Given this list of marker genes VIPAS39, GSTP1, TUBGCP3, PHTF1, SH3BP5, SSNA1, GPNMB, PSPH, CRY1, ALG2, GADD45B, DERL2, PPP4R3A, ABCB8, PDE8A, DHX8, LINC02599, EIF2S3, EMC3-AS1, NEK10, CHROMR, ADRM1, TRIP12, LINC01270, PES1, SNRNP35, ATP5MC1, ZNF26, HEY2-AS1, ZSCAN31, TMEM11, C6orf226, RECQL5, RN7SL371P, GLYR1, TREX1, SRPRB, FAN1, ZNF621, ATF1, GAPDH-DT, INO80D-AS1, RPS24 (NCBI Gene Id 6229), RTCA-AS1, SLC16A13, PPP6C, SETD4, RNF212, ATG4A, CD109, NEDD8, PDCD6 (programmed cell death 6), RETREG3, AHI1-DT, EDC3, MED24, TOP3A, INVS, HSPA4, ZNF213-AS1, MUC20-OT1, DCAKD, ASXL1, CYTH1, PPP2R3C, RBM27, APOC1, ZNF592, SNRPD2, LINC00824 (long intergenic non-protein coding RNA 824), C1orf174, ZRANB2-DT, TBC1D19, SMC6, CASP8 (caspase 8), SULT1A1, EPDR1, SLC22A4, GOLGA2, TBC1D2, RHBDD3 (NCBI Gene Id 25807), LINC01287, SAR1A, PABPN1, LOXL1-AS1, IPPK (NCBI Gene Id 79194), CCT6A, MLEC, SUCLG1, NEK4, BRF2, PITPNB, PDXDC1, ZBTB38, ARIH1, HM13, AP2A2, CLN8, TCEANC2, ZNF207, GRAMD1B, SLC25A28, AFP, MRPL37, GCC2, GEN1, ARHGAP19-SLIT1 (NCBI Gene Id 100533184), ZSCAN26, MMUT, ENSG00000268460, SLC35E1, ZNF107, FOXN2, TCF7L2, CDKN2AIPNL, PSMD8, TMOD3, NXPE3, TIA1, DNAJC27, LINC02331, GTF2F2, RPL34, EHD1, COPS4, TNIP1, RNU6-304P, EHMT1, NUDC, TOR2A, LINC01888, CSTF1, CRAT, PTPDC1, EIF3L, C17orf75, HMGXB3, DYNLT2B, PMP22, SMIM7, ATG12, ENSG00000239142, LSG1, ENSG00000227101, MAP4, NAGPA, SLC7A5P2, MNT, PIPOX, BTF3 (NCBI Gene Id 689), LRP6, COQ8A, SLC25A28-DT (NCBI Gene Id 123466211), SLC48A1, ZNF148, COL7A1, CCDC18, ABHD17B, MAFG, DMRTA2, GBE1, GPRIN2, PHF12, ASCC1, PLA2R1, SAV1, RPL22L1, ENSG00000227496, CASC3, SLTM, AIDA, ANKHD1-EIF4EBP3, TDP2, NAXE, TSC1, MIS12, LANCL2, CCDC88B, POLR1G, CSNK1D, SAMD4B (sterile alpha motif domain containing 4B), KIAA1191, FAM219A, RHOA, LINC02065, MIR3912, UAP1-DT, CENPO, MAP3K3, CCDC18-AS1 (NCBI Gene Id 100131564), GNG12-AS1, MEPCE, ASH2L, RPS23, UBIAD1, SDAD1, IFRD1, RPL5, SLC7A11, GFM1, SLC39A9, PARP2, GSTM4, SPAG16-DT (SPAG16 divergent transcript), DNAI1, BHLHE40-AS1, UFL1-AS1, TMEM68, LINC00706, SNORD101, C17orf100, LINC03014, SRD5A3, LOXL1, CD63, UGGT1, BCYRN1, RNU6-92P, METTL16, PCGF1, RFFL, RAB3GAP1, ENSG00000267882, SLC35D1, PVT1, ITPRID2, ATP6AP1L, RBFA, ENSG00000266401, ZNF180, CDKN2B-AS1, SQSTM1 (NCBI Gene Id 94002), DNAJB9, XRCC5, AK5, CSF1, FAM204A, NTRAS, GEMIN8P4, LSM10, MIR4710, CEP112, USP15, POLR3F, LINC00322, RNU6-313P, RBM4, AIFM2, DGUOK, C2orf68, TM4SF19-AS1, SEC31A, NAA38, UFD1, TTBK2, EPC1, PI4KB, PCBP1, SEC24C, ECI2, MSRB1, MED31, YJU2 (NCBI Gene Id 55702), SERP1, RTEL1, ENSG00000203987, OIP5, TMEM44-AS1, HSPA5-DT, YWHAG, LAMB3, ANKHD1-DT, TAX1BP1-AS1, RBM3, TBCK, HNRNPA1, NSUN4, LINC02006, LRRC57, RNU6-1276P, TUSC1, NDUFC1, TMEM242-DT, ZNF764, FRMD4B, ZNF346, CDC23, SERBP1, YWHAE, ATP5F1B, NSL1, TNFAIP1, ALYREF, DLGAP1-AS2, PIGU, AP3S1, TINAGL1 (tubulointerstitial nephritis antigen like 1), RPL6, ARL1, PPIP5K2, CFLAR, SPTA1, AMBP, PISD, RAB24, ZNF451-AS1, VCP, PIR, ABHD12, ZRANB2 (zinc finger RANBP2-type containing 2), GTF2A1, RIC8B, SRSF2, ENO1, NUMBL, MBD4, TSC22D1, CCT8, CKS1B, SH3GLB1 (NCBI Gene Id 51100), TMED5, VPS26C, TMEM167A, ENSG00000187185, MYSM1, KBTBD4, ZSCAN22, SNHG29, CUX1, ENSG00000293341, TRIM4, ANK1, TSEN15, MIR4482, DOHH, ARL6IP6 (ADP ribosylation factor like GTPase 6 interacting protein 6), GABARAPL1, TANK, UTP18, TBC1D14, H4C8, COX14, GAPDH, PIN4, TAFA2, IFT122, NAA80 (N-alpha-acetyltransferase 80, NatH catalytic subunit), ZNF594-DT, CYP2R1, SNRPE, ZNF574 (NCBI Gene Id 64763), PAK1IP1 (PAK1 interacting protein 1), OSMR (NCBI Gene Id 9180), DCAF12, RHOF, EIF1, GYG1, VDAC2, ANXA6, BICD2, ACTR3C, ABCF3, ABHD16B, TRIM25, RABGGTB, BECN1, MIR4754, TACC2, CIAO3, GGNBP2, DDX42, RORA-AS1, AP1G1, WDR19, UPF2, C19orf53, C2orf49, NUP85, ZNF524, TAGLN2, RARS1, INPP5B, HSPA5, CARS1, WDR13, ZNF383, ATG16L2, PJA2, KNTC1, ZNF2, ZBTB20, RNPC3-DT, MXD1, LINC01063, CCDC102B, UPF3A, RPL27A, RNU6-1, GOLGA1, DDX23, GNL1, AHCYL1, MDH2, AFG3L2, PEF1-AS1, REXO1, BACH1, LINC00466, SMG1P3, HEXIM1, CNPY4, THAP9-AS1, VTI1B, SCYL3, JPT1, NADK, CRPPA, NMT1 (N-myristoyltransferase 1), POLR2A, ACTR8, HSPE1, SNAP25-AS1, STAM2, TMEM87A, TRMO, PIP5KL1, MTRR, GFI1B, GTF3C2-AS2, CTSA, SNORA57, MICOS10-NBL1, GNAL, BLMH, SLC1A1, WHSC1L2P, TXNL4A, PSMD10, CANX, WDR5B-DT, NTPCR, ADM-DT, USP39, STC2, TPM4, CASP6, BNIP1, TYRP1, WAC, MPDU1, TCAIM, SAP30BP, KIAA1328, SPRED1, GMPR2, PSMC3, FAM187A, ANKRD54, AKT1S1, FKTN-AS1, STAM, SBNO1 (NCBI Gene Id 55241), PSMD9, IQCG, DNAJB4, DCAF8, NDUFA4, ZNF619, SMC3, PSMB3, EEF1AKMT3, ABT1 (NCBI Gene Id 29777), TUBG1, CHCHD3, DENND4A, VEZF1, PDAP1, RHEBL1, APBB2, ACTMAP, LUC7L3, PRR5, FAM133B, DHRS4-AS1, MIPOL1, TUBA4A, TALDO1 (NCBI Gene Id 6888), MTMR2, UHMK1, VPS52, PCCB, MPDU1-AS1, SLC39A7, COQ8B, GGPS1, CDK11A, PIK3R4, B3GAT3, SRP14-DT, LRP1B, CWC25, ARPP19, SPTAN1, GPI, NEDD8-MDP1, EXO5-DT, SETDB2, RAD52, RNF19A, USP54, ATF7IP2, ASB6, MDC1, PIERCE2, SPRTN, DNAJB12, LINC01732, ANKRD18A, MRPL17, ATP1B1, PPRC1 (NCBI Gene Id 23082), NUP107, UACA, MT2A, DALRD3, BOD1L1, TOPORS, TMPO, HSP90AB1, MCTS1, RETREG1, GPATCH4, ENAH, SLX4IP (SLX4 interacting protein), MIRLET7IHG, RAPGEF3, TMEM217, SNCG, MCCC1, OXA1L, DAG1, NUDT9, PDCD6IP, LINC01269, MTLN, SNRPA1, PSMG2 (proteasome assembly chaperone 2), SF3B3, DPY30, RAD17, TM4SF19, PSMD3, EFL1P1, DOLPP1, DHPS, TM9SF1, ADAP2, SRP14, GDPD5, SLC30A5, HMGCL, MANF, CNPPD1, DMGDH, TMEM183A, ZNF503-AS2, MYL12B, EXD1, CWC27, TSNAX-DISC1, ARAP1, PSMA4, CAPRIN1, PUS10, DOLK, SLC26A1, ZMYND12, COQ10BP2 (NCBI Gene Id 100421072), KANSL2, ZNF585B, ANTXR2 (ANTXR cell adhesion molecule 2), RRN3, COMMD6, PRSS23, POLR3B, NOA1, EIF1B-AS1, COASY, HSPA9, MRPL18, KRIT1, KLF2-DT, TMEM116, ZCRB1, VPS25, SMG7-AS1, NADK2, TTC41P, NDC1, IWS1, ZDHHC13, TOX4, CD58, SNRPD1, ST13, C22orf39, SESN1, LINC03125 (NCBI Gene Id 100508107), NQO1-DT, RNU6-370P, SRP19, YY1AP1, STXBP1 (NCBI Gene Id 6812), ZNF446, FBXO36, SMIM27, TEX19, HMGN2P7, BROX, RNA5SP473, MTAP, ZNF320, AGA, ECE2, WARS2-AS1, MICU2, WDR76, GOLM2, CDC45, ZNF230-DT, GLRX, SIL1, HDGF, ARHGAP32, MEF2C-AS1, PSMD11, DDX6, CCDC171, STK16, CAAP1, VPS50, CARD8-AS1, CDCA3, SEC23IP, SLC2A2, CROCCP2, LIN54, EFTUD2, MIR4638, TNRC6A, P4HTM, RNF213-AS1, LINC00342, DOCK8-AS2, CEP20, RPL30, OSBPL9, ATRAID, UBC, CD151, RB1, MIR3677HG, NANOS3, BOLA1, HEY2, B3GALNT2, NRG4, TMEM11-DT, ATF3, NRDC, RNU6-430P, PNISR, FOS, SLC25A11 (NCBI Gene Id 8402), AAAS, MIR5188, PSMD14, LINC00881, DUSP21, PRDM10, TAF8, EFCAB2, MAPK6, GNB2, NACA, TRIM16, JRKL, ACOX1, SOX6, MRPL39, PRPF40A, KRT8 (keratin 8), ATP5MC2, STRIP1, GTF2H3, RNU6-951P, RPS15A, PRPF38B, COX7A2L (cytochrome c oxidase subunit 7A2 like), KPNA5, ALG5, TMEM42, RNF167, MGST3, ITIH4, ITGB5, HEXIM2-AS1, CEP170, TM2D3, ID1, RN7SKP114, ITGB1, TBK1, ERC1, PRR3, RBM19, CCDC59, TXNDC11, LENG8 (NCBI Gene Id 79162), CNBP, PPM1D, PSMC5, AQP3, ZNF260, FHAD1, KANSL3, SELENOI, NELFA, ATAD5, PLEKHM3, LARP4, IARS1, PDCL, CDC7, NCL, PURB, KMT2E, OXA1L-DT, MIR4766, CIRBP, ZNF566, CLTC, NUP188, CELF6, ERH, TM4SF19-DYNLT2B, EXOSC8, ARID4B, LNCTSI, DAD1, ANKRD42-DT, PAAF1, FRG1HP, OLMALINC, KLHL20, GABPA, USP33 (NCBI Gene Id 23032), ARRDC1, MVK, ARHGAP19, C9orf85, RHEB, TSFM, EXOSC1, TAF1D, C11orf54, PADI4, IDI1, ZNF518A, SMCHD1, NSRP1, TMEM260, UROD, BLM, MSANTD3, BAG6, TUSC3, RNF145, ZNF140, SLC38A4-AS1, DPP3, CHMP3, SLC25A37, MRFAP1, MSL2, TPRA1 (NCBI Gene Id 63108), ENOX2, ANAPC16, WBP1, SHC4, NCOR1, SDHA, SLC25A21, EGLN3, EGF, DHX29, BRD2, LINC01089, TPRXL, PUS7L, UBB, DAZAP2, ATF6-DT, PXMP4, TOR1A, CDK5RAP2, CAND1, TMEM179B, LINP1, NKIRAS1, VTRNA1-2, UBE2R2, RNU6-416P, SLC9A1, FKBP14-AS1, UAP1, THAP5 (THAP domain containing 5), C1orf198, MPC2, MEAF6, NFE2L3, ADGRF3 (NCBI Gene Id 165082), RXRB, XRCC6, ARL4A, RRN3P1, FRAS1, ALDOA, RBM14-RBM4, TUBB, IL6ST-DT, TCTA, SELENOF, NPM1, ZNF678, COPZ1, RNA5SP283, SH3TC1, SLC41A2, PTK2, SRRM2, KIAA1143, CNIH4, TAX1BP1, PTP4A2, SSR1P2, EIF3J-DT, G3BP1, PLD6, KBTBD2, NR6A1 (NCBI Gene Id 2649), CCDC159, CSNK1A1, HTATSF1P2, RMDN1, QPCTL, IGF2BP3, COX7C, RNU6-7, KDM4C, UFC1, NFE2L2, CCDST, PSMD12, U2SURP, RBX1, ZFPM2-AS1, RPS13, LINC00630, ZNF426, PROSER3 (NCBI Gene Id 148137), ZFAND3, YOD1, CBR4-DT, WDR41, WDR37, COG4, GFUS, WWTR1, ERP44, RPSAP65, MAP2K3, RPA2, ATL3, ABCC5, TBC1D9, ZCCHC9, SMARCD1, TBC1D16, CLEC2D, METTL18, ZNF197, AKR1D1, CAP1, UBE2I (ubiquitin conjugating enzyme E2 I), FTX, S100Z, GALK2, CDC42EP2, HRH1, WAC-AS1, DCUN1D3, MTF2, LINC00471, TBC1D22B, EWSR1, ALG1, BACH2, INTS13, RTEL1-TNFRSF6B (NCBI Gene Id 100533107), SLC1A5, ZMPSTE24, GSN, BABAM1, DUSP10, ADAMTS1, SUGT1P1, PPP2CA, TMEM18, HCG27, BANP, DYRK4, CCNI (NCBI Gene Id 10983), HELLS, REPS1, FBXL6, RAD9B (RAD9 checkpoint clamp component B), EXOC8, ELOB, ATP13A1, TRUB1 (NCBI Gene Id 170561), XRRA1, ALDH3A2, LINC00431, RIMOC1, SPINK13, C19orf48P (chromosome 19 open reading frame 48, pseudogene), ZNF3, STARD10, ANKHD1, MED18, VPS35L, CSE1L-DT, NDUFB1, MYO5C, EIF2AK3-DT, VEZT, ZNF497-AS1, POLD3, C1S, CAPN2, GRK1, SLC39A13 (solute carrier family 39 member 13), RPL21P21, ADGRG1, EMC4, EIF5-DT, CNTRL, RPL7L1, FLVCR1, ZNF251, PPCS, RSRP1, POLR2B, AVPR2, GNPDA1, HMBS, MRPS22, FKTN, GTF3C4, AK6, ANKRD13C, ANAPC11, NHERF2, STAG2, PRELID1, UNKL (unk like zinc finger), SKAP2, ERCC8, SLC30A6-DT, HOMER2, MBTD1, DR1, LRRC28, ENSG00000233461, BIN1, PTRHD1, CACTIN, CCPG1, RMC1, WDR5B, ARHGEF37, KIAA1217, RBM28, MED20, BRIX1, MYG1-AS1, PSMB6, ALG3, CLIP1, UBE2Z, CEP57L1, RAD23A, C14orf93, SHLD3 (shieldin complex subunit 3), NIBAN2, LIPT2-AS1, FAHD1, DPP3-DT, ATG13, SRSF1, MRPL45P2, PTPN22, SRP68, PPP1R8, MITD1, AHI1, HTATIP2, ZNF432, API5, TPI1P2, PRRC2C, CCDC127, RPS12, C6orf52, PPP2R2A, SLCO2B1 (solute carrier organic anion transporter family member 2B1), WDPCP, METTL17, GANAB, PCGF3-AS1, RPL12, ITPR3, NUP107-DT, SHC1, MYNN, THAP9, TIMM17A, SEL1L3, ZFAND3-DT, USP14, ZNF473CR, SHMT2, TTC17 (NCBI Gene Id 55761), NCLN, FAM13B, BUD31, BFSP1, MSTO2P, CLCN3, MTND5P23, LGALS8, ZNF226, TENT4A, NGRN, RBM12B-DT, IDH3G (NCBI Gene Id 3421), BTF3-DT, MIR4458HG, CYC1, CBX3P2, IREB2, MCM2, RPS6, ANAPC2, RHCE, MRPS14, MIDEAS, MST1P2, MIR3199-2, PCIF1, TNPO3, APPL2, CPEB3, ZNF426-DT, METTL25 (methyltransferase like 25), TIMM17B, QRSL1, NLRP1, ENSG00000273162, LINC02842, NEURL2, MRPL30, XPNPEP3, ARPC5L, SAP30, TASOR2, ZNF16, SMARCAD1-DT, UST-AS2, STMN3, PLEKHG1, SREK1IP1 (NCBI Gene Id 285672), CPEB4, ANKIB1, HNRNPUL1 (heterogeneous nuclear ribonucleoprotein U like 1), CRY2, CCND3, PTMA (prothymosin alpha), NDUFAF3, TMEM37, MIR6781 (NCBI Gene Id 102465468), CHMP4C, L3HYPDH, HECTD3, HADHB, FGD6, MMADHC, HDHD2, MICOS10-DT, SKA3, GPBP1L1, ZNRF3-AS1, RPL12P38, STYXL1, CYB561D2, TEAD4, LMNA, ZNF224, MRPL57, EPC1-AS1 (EPC1 antisense RNA 1), NCKIPSD, SS18L1, CLK1, PRDX5, FDFT1, DENND3 (NCBI Gene Id 22898), CHAC1 (NCBI Gene Id 79094), SNORD15A, RBAKDN, MTREX, RPS27A, NHSL1-AS1, NORAD, KLHL7, ANKRD17, RPAP3, ALDH3B1, KDM3A, FAM168A, ANAPC7, MED17, BHLHE40, ST3GAL1-DT, JMJD6, TNFSF9, GOLGA5 (golgin A5, NCBI Gene Id 9950), CLPTM1, ZNF100, SPTY2D1, ZNF213, VGLL4, MFSD11, ATR, SBNO2, GTF3C2, RPL34-DT (NCBI Gene Id 285456), TBL1X, PGD, RFX3-DT (NCBI Gene Id 101929302), SEC11C, MIR200CHG, KMT2E-AS1, SLC6A6, MDH1, SART3, CPNE4, TRMT44, HARS1, MYO15B, AMPD3, SMCR8, SLC36A4, PHPT1, ASH1L, NHSL3, TRAPPC13, PSMB5, EIF2B2, CLASRP, SERPINB9P1, SLC12A8, SCAPER, CCNL1, SEM1, RPS8, ENSG00000268129, MED1, CDKN2A, ADNP2, SEC11A, SPAG7, DDX20, SLF1, ILF3, QARS1, PLK3, C1orf216, XPC-AS1, CYB5RL, KIDINS220, AKR1B1, MALAT1, CPSF2, TATDN3, SRCAP, HIRA, SHOC2, MPZ, KRT18, H2AZ2, DDX3ILA1, RNA5SP122, DZANK1, ANKRD1, RPL21, BRAT1, BCKDHA, MYH9, AGPAT4, RPPH1, NUTM1, PSMC6, COQ5, GMFB, ARHGAP25, TRIM23, BTG2, CD59, CBFB, EIF3D (NCBI Gene Id 8664), ANKRD42, MBNL1 (NCBI Gene Id 9850), MIR3661, SNRPG (NCBI Gene Id 6637), EIF1B, MYOSLID, GAS8, ZNF514 (NCBI Gene Id 84874), DCAF8-DT, HMGN2P34, ANKRD13D, APOLD1, LINC01258, PSMB4, DIP2A, HARBI1, COPB2, DGKA, MCM5, CCDC43, ILF3-DT, ZNF200, PARN, HDAC4-AS1, TBRG4 (NCBI Gene Id 9238), SPP1, CHCHD4, SLC16A1, PYM1, GOPC, TMBIM6, LEMD3, ATG4C, NOL7, SEC24A, CIRBP-AS1, GUF1, DENND5B, ZNF780B, ZNF623, PPP1R13L (protein phosphatase 1 regulatory subunit 13 like), PAIP2, RACK1, CLHC1, PNKD, NDC80, ANKRD28, WDR74, EBF1, ACAP3, RAB30, SLC52A2, UBE3D, EPM2AIP1, ANKRD13C-DT, NUSAP1, DAP3, VPS29, BAG4, H2BC5, NCOR2, PSAT1, WDSUB1 (NCBI Gene Id 151525), HECTD1, SH3BGRL3, GOSR2-DT, VPS4B, ENDOV, PAFAH1B1, LINC02984, PPP1R15B, PDCD6-DT, COA4, TRA2A, BLCAP, RN7SL1, IL1R1, RPTOR, FTSJ3, FIGNL1, RPL5P24, BTNL12P (butyrophilin like 12, pseudogene), ZCCHC17, H3-3B, HSPB6, DLGAP1-AS1, DBF4B, ZNF546, PLEKHM1, LRRFIP2, TPD52, NARF, LYRM7, OXCT1, CLCF1, TARS1, SAMD9, LAMC1, INO80, SLC25A36, ACTG1, PEX13, HSD17B4, SAP30-DT, BTG2-DT, CKMT2-AS1, PSMA5, TMEM69, ZRSR2, PLCXD2, SMARCAL1-AS1, TINF2, AP4B1, LINC02960, FARSB, ANGEL2, ABCC8, ME1, SLC16A1-AS1, HNRNPD, PSMB7, KCTD20, XRN1, EMC3, MORF4L1, CREB3L2, NUP54, TET2, PPCDC, RBBP5, RPS3, KDM5C, CBX5, CHP1, UPP1, SMYD3, TGFBI, USP10, SMARCAL1, CBR1, TROAP, NUFIP2, SLX4, CWC22, NUDT17, AUNIP, EIF3M, MIR4727, PPP1R18, TTC8, GART, ASB3 (NCBI Gene Id 51130), HYAL3, ICE1, PPT1, FBXL19, PIGN, UNC45A, NANP, PPP4R3B-DT, SEPTIN9, LUCAT1 (lung cancer associated transcript 1), DGAT1, IRAK4, HTR1D, RPL35A, SH2B1, PLCD4, CCDC82, LYRM4, RN7SL198P (RNA, 7SL, cytoplasmic 198, pseudogene), COX20, EXOSC10-AS1 (NCBI Gene Id 105376736), TPSG1, ZNF770, TRAPPC8, MKRN2, SNX13, SEC61B, BTN3A2, DENR, MCMBP, PPME1, C3orf52, ADM (NCBI Gene Id 133), LINC01271, TNXB, ZC2HC1C, SNRPA1-DT, PSMA1, ABL1, RBM14, HACD3, PBLD, GSE1 (NCBI Gene Id 23199), ACO2, DCTN4, FAM174B, HDAC4, ENSG00000275740, TRIM16L, TFE3, MKLN1, USE1, AIMP1, CYP4F11, TMCO1, NDUFS3, PTGES3, CSKMT, DCAF6, COPB2-DT, RIN1, FNBP4, LY6S-AS1, NARF-AS2, TOM1, LAMP1, NR2C2AP, GOSR2, PAQR5, SLC25A45, MRPL40 (mitochondrial ribosomal protein L40), PSME3, ITPR1, CCDC103, CCDC9B, SETD1A, PCAT14, CLIP4, ENAM, KIF15, TMEM18-DT, EXO5, RAB2B, PSMA7, TOMM40, RPRM, SON, SLC49A3, EIF2AK3 (eukaryotic translation initiation factor 2 alpha kinase 3), CHCHD2 (NCBI Gene Id 92547), PRORP (protein only RNase P catalytic subunit), CELSR1, ARFGAP2, ATAD2, FAM200B, SEPTIN7-DT, TPGS1, NFE4, LINC01132, PPP4R1L, ZNF263, RNU7-27P, S100A2, SPAAR, EIF3J, PPP4R3B, NAPRT, NVL, POC5, PRKCI, MIR5091, SSR4 (NCBI Gene Id 6748), LNCATV, TAF6, KANK1, STAT1 (NCBI Gene Id 6772), RBM8A, UTP11, GLB1L, FIZ1, MAN2C1, P4HB, FAM13B-AS1, SPG11, DHX30, ZBTB26, ARID1B, CTDSPL2, PCBP1-AS1, RPS19BP1, USP40, RTCA, RNASEH2C, AURKA, TGOLN2, CCDC66, GIPC2, FBXO33, KLHL21, AP2B1, AHCY, ODR4, VMP1, MARCOL, HRG-AS1, ALKBH1, NR3C1, ACADL, TMEM128, ENSG00000277020, BCAN-AS2, EEIG1, PROS1, SNORD55, ZNF138, NDUFA6-DT, SPART-AS1, BTBD19 (BTB domain containing 19), HYCC2, STK40, UBE4B, SMG7, GABPB1-AS1, TXN, C6orf62, RAMAC, SYS1-DBNDD2, H2AZ2-DT, RETREG2, RNA5SP222, PATL2, FBXW7, ASCC2, EIF1P2, FAU, HSPA1B, PCF11, NICN1, TANK-AS1, NR4A1, WTAP, THRAP3, CASTOR3P, SMARCA2 (SWI/SNF related, matrix associated, actin dependent regulator of chromatin, subfamily a, member 2), METTL4, PER1, VTRNA1-1, NPRL2, ZNF227, ZMYM5, LYRM1 (LYR motif containing 1), CCDC90B-AS1, EIF6, PPP1R2, SVBP, MLH1, RAPGEF6, SEPTIN7, PDK4-AS1, MRPL42, BMPR1A, NTMT1, PTPA, PEF1, DNAJA1, GFPT2, LINC00426, HSPE1-MOB4, TKT, PFDN4, CEP76, GSTO2, NPLOC4, TMEM138, TOR4A, MAILR, ZNF331, SSR1 (signal sequence receptor subunit 1), HADHA, KAZALD1, RABEPK, ZBTB4, RPL37A-DT, ECH1, RAD1, RPS18, MICOS10, RPSAP28, GMEB1, LENG8-AS1, TRMT112, MINDY2, MTMR4, ARMC5, SNORD45C, IP6K2 (inositol hexakisphosphate kinase 2), LINC00332, EIF2B1, WASHC4, HMGB2, PUM1, OPLAH, DGCR6L, ZNF337-AS1, NEU4, MRPS17, FIRRM, HOOK2 (NCBI Gene Id 29911), EXOSC2, TFCP2, IKBKB-DT, DYNC1LI1, RPN1, MYO19, ASB9, HERC1, C2CD3, TOR1B, TGS1, CCNB1IP1, ABCC5-AS1, NDUFB3, CBR4, FAM201A, TMEM198B, RNU1-62P, EIF4A2, TPR (NCBI Gene Id 7175), ALKBH5, RALGDS, SARAF, CREBZF, ABCC3, NHLRC2, SUPT20H, MCL1 (MCL1 apoptosis regulator, BCL2 family member), RAD23B, PSMD2, WIPF1, ARL13B, SRSF11 (NCBI Gene Id 9295), RPRD2, ZNF274, SMC4, OR4K17, EIF2A (eukaryotic translation initiation factor 2A), LNC-LBCS, ZNF420, ARF4, MMAB, IL6ST, TEDC2-AS1, FECH, GSDMC, LYSMD3, FNDC3A, CYB5D1, ZNF302, FBXL13, LINC00547, ERI2, SPART, TRIM52, PCGF5, CLN3, HSPA8, CRTC3 (CREB regulated transcription coactivator 3), CLPX, ATF4, ID3, CCDC25, SETD7, SSX1, CHEK1, TCP1, SMARCD3, DCLRE1B, TBC1D17, FASTKD3, VPS45 (vacuolar protein sorting 45 homolog), SFT2D3, PPP6R1, RPS11, NDUFAF2, SYS1, KIAA0930, LSM1, MRPL47, RSRC1, CCN1, ATP5PF, TCEA2, SMARCE1, LINC02159, TRIM41, RAVER1, STAM-DT, THAP1, MEF2A, COQ9, RGS20, SNORD100, SERPINB5, LRRC58, RPS5, AKNAD1, B2M, SNHG30, SLIRP, SUPV3L1, SPCS2, JKAMP, ZNF814, RTN4IP1, SLC5A6, AKR1C3, TXNRD1, SMIM20, GPAM, BMERB1, ZDHHC18, ZDHHC16, ATP6V0A1, HNRNPA0, ASPSCR1, AKAP8, ACTR3-AS1, TAF9, ZEB1 (zinc finger E-box binding homeobox 1), MAGOHB, ANP32E, SNHG5, YKT6, ZNF530, GPR146, ACTB, EEF1G, USP34, TMEM202-AS1, RLF, CACYBP, NOP53, NDUFB5, RNPS1, SCD, OR8B9P, PIGT, CNN3, NDUFA6, NQO2, ZCWPW1, IKBKG, TMEM170A, ZNF326, RPS9, METTL1, HS2ST1, SZRD1, GCLM, PHF5A, CYB561A3, RUNX1, DET1, DYNLRB2, ZFAND5, CRTC3-AS1, ST7L, RBM4B, PMEL, MATR3, UBAP2, FARS2, HEPH, PRMT5, CCDC47, NQO1 (NCBI Gene Id 4834), USP5, MKKS, EEF1A1, SNORD95, ZBTB21, NEAT1, ENSG00000273077, MDM4, CCDC124, RNPC3, TMEM59, RFX3, MACO1, SNORD59A, HEXIM2, AHSA1, OSBPL10 (oxysterol binding protein like 10), SVIL, TSNAX, SPAG16, BCLAF1, CLU, DESI1, CRYGN, SNX1, RNU6-8, KMT5B, ASB8, LINC01975, NDUFAF4 (NADH:ubiquinone oxidoreductase complex assembly factor 4), ZBTB45, FRG1CP, NR4A3, RNF13, BNC2, SREK1, CYYR1-AS1, TRAPPC3, PSMD14-DT, SULT1A2 (NCBI Gene Id 6799), FBXO28, SNORA33, TRMT12, BBS1, CDK7, PQBP1, PLD3, RPL37A, WARS2, KLHL7-DT, RSRC2, NKIRAS2, EXOSC5, ALS2, SRSF10, HARS2, USF1, ST3GAL1, ERCC1, PLEC, DDB2, GANC, CCL2, MEF2AP1, ZBED5, CCT5, DONSON, DNM1, C1GALT1, RNU6-535P, HSP90B1, ERLEC1, HAGH, NFE2L1, NAGLU, TM9SF4, KPNA4, RAB5B (NCBI Gene Id 5869), MEF2C, UBN1 (ubinuclein 1), SNX9, ENSG00000257732, PLA2G6, ARID1A, EIPR1, RBM25, SKP1, SMIM13, RELCH, KRT17, MRPS18B (mitochondrial ribosomal protein S18B), NME6, SNRPA, YTHDC2 (YTH N6-methyladenosine RNA binding protein C2), GNG4 (NCBI Gene Id 2786), TRPC4AP, RHBDD2, LBR, AMIGO2, SMARCAD1, LRSAM1, CORO7, IL6, ORC2, AP4E1, C11orf98, NMRAL2P, RBM15, BNC2-AS1, PSIP1, DENND3-AS1, MTPAP, ZNF669 (NCBI Gene Id 79862), FMN1, here is a description of the gene set: studied in species Homo sapiens from publication Yevshin I, Sharipov R, Kolmykov S, Kondrakhin Y, Kolpakov F (PMID 30445619) Human Gene Set: NFE2L1_TARGET_GENES Genes containing one or more binding sites for (NFE2L1) in their promoter regions (TSS -1000,+100 bp) as identified by GTRD version 20.06 ChIP-seq harmonization.